Given this list of marker genes IFI44L, SIGLEC1, IFI6, IFI27, EPHB2, SERPING1, LY6E, LGALS3BP, HESX1, LINC00487, here is a description of the gene set: from publication Kazmin D, Nakaya HI, Lee EK, Johnson MJ, van der Most R, van den Berg RA, Ballou WR, Jongert E, Wille-Reece U, Ockenhouse C, Aderem A, Zak DE, Sadoff J, Hendriks J, Wrammert J, Ahmed R, Pulendran B (PMID 28193898) species: Homo sapiens Genes up-regulated in peripheral blood mononuclear cell immunized with ARR vs immunized by RRR in unknown (primary immunization with recombinant adenovirus 35 (Ad35)) after exposure to P. falciparum RTS,S/AS01, time point 1D RTS,S is an advanced malaria vaccine candidate and confers significant protection against <i>Plasmodium falciparum</i> infection in humans. Little is known about the molecular mechanisms driving vaccine immunity. Here, we applied a systems biology approach to study immune responses in subjects receiving three consecutive immunizations with RTS,S (RRR), or in those receiving two immunizations of RTS,S/AS01 following a primary immunization with adenovirus 35 (Ad35) (ARR) vector expressing circumsporozoite protein. Subsequent controlled human malaria challenge (CHMI) of the vaccinees with <i>Plasmodium</i>-infected mosquitoes, 3 wk after the final immunization, resulted in ~50% protection in both groups of vaccinees. Circumsporozoite protein (CSP)-specific antibody titers, prechallenge, were associated with protection in the RRR group. In contrast, ARR-induced lower antibody responses, and protection was associated with polyfunctional CD4<sup>+</sup> T-cell responses 2 wk after priming with Ad35. Molecular signatures of B and plasma cells detected in PBMCs were highly correlated with antibody titers prechallenge and protection in the RRR cohort. In contrast, early signatures of innate immunity and dendritic cell activation were highly associated with protection in the ARR cohort. For both vaccine regimens, natural killer (NK) cell signatures negatively correlated with and predicted protection. These results suggest that protective immunity against <i>P. falciparum</i> can be achieved via multiple mechanisms and highlight the utility of systems approaches in defining molecular correlates of protection to vaccination. Human Gene Set: KAZMIN_PBMC_P_FALCIPARUM_RTSS_AS01_UNKN_AGE_IMM_WITH_ARR_VS_IMM_BY_RRR_PRIMARY_IMMUNIZ_WITH_RECOMB_ADENOVIRUS_35_1DY_UP